The following is a description of a gene set: Human Gene Set: GSE32164_RESTING_DIFFERENTIATED_VS_ALTERNATIVELY_ACT_M2_MACROPHAGE_DN Genes down-regulated in macrophages: resting differentiated versus alternatively activated M2. studied in species Homo sapiens In response to microenvironmental signals macrophages undergo different activation, indicated as classic/M1 and alternative/M2 polarization. C-Myc transcription factor could be an essential player in M2 polarization. Functional relevance of c-Myc in M2 macrophage biology is investigated by evaluating the effect of 100-58F4, on the transcriptional profile induced on human macrophages by IL-4. from publication Pello OM, De Pizzol M, Mirolo M, Soucek L, Zammataro L, Amabile A, Doni A, Nebuloni M, Swigart LB, Evan GI, Mantovani A, Locati M (PMID 22067385), and this is the list of marker genes: RNF181, FBXW4, IL10RA, ETS1, SPG21, MPEG1, TMEM59, TSPAN32, RABAC1, FGL2, RPN1, RNGTT, ICAM1, CD82, CD28, MRPS5, IL4, ZFP36L1, CD22, MYCBP2 (NCBI Gene Id 55685), EIF4G2, CCR2, CXCR3, HLA-DRB1, EVI2A, PPID, HSPA5, PSMB9, HLA-B, ANXA1 (annexin A1), XPO1, UBE2D3 (NCBI Gene Id 7323), ID2 (inhibitor of DNA binding 2), HBB, E4F1, HLA-DQA1, SBF2, ST3GAL6, ANTXR2, VAMP5, SOCS2 (suppressor of cytokine signaling 2), SOAT2, F2R, CCRL2, DDX51, SKIC2 (SKI2 subunit of superkiller complex), ENTPD1 (ectonucleoside triphosphate diphosphohydrolase 1), ITGB2, PRDM1, SLC44A1, CYBA, PTGER4, TNK2, FASLG, ACTR2, COMMD7, RGS2, HPN, GOLGA5, JCHAIN, IRF5, C9orf40, BLK, PRKCD, BCL7B, GPC1, ARIH1, IL18RAP, MDFIC, DGAT1, PLBD1, SMPDL3A, ENPP1, ASNSD1, RNF34, RIN2, HLA-C, VOPP1 (NCBI Gene Id 81552), PTTG1IP, CYRIB, BHLHE40, GBP2, MFSD14A, CCR5, BCAP31, ITM2C, CRLF3, GNG10, AKAP8, UPF3B, COL5A1, PRDX6, FICD, SMNDC1, NABP1, AHNAK, ZBTB20, SPATA13, LMO4, CASP7, DNAJB9, HOPX, RAB24, BCL2A1, BTG3, KCTD12 (NCBI Gene Id 80710), NUDT16L1, ATF1, G3BP2, NRP1, KLRG1, MRPL44, GRK5, TK2, IL7R, CDC42SE2, SRGAP2 (NCBI Gene Id 440748), GATA3, ITM2B, RAB14, CLCN4, RASSF2, CUL3, LDAH, CKB, CASP8, TNFRSF18, PLIN2 (perilipin 2), EI24, CSTF3, RNF11, JKAMP, CDIPT, ASRGL1, MMP9, OTULINL, GPN3, EEA1, RNFT1, NMB, LMO2, FNTA, SEPHS2, EYA2, BMAL1, CYFIP1, HGSNAT, TENT5C, IGKC, ULK1, AP1G1, RELB, PPP1R15B, IREB2 (iron responsive element binding protein 2), TULP4, ERCC3, TMEM176A, RNASE4, CTSH, PLEKHB2, OSER1, SFT2D1, MARCHF6, CD72, UIMC1, IL10RB, TRAFD1, TRIM11, IFNG, KLRK1, PSEN2, DOK2, SLC4A7, IL18R1, SERPINB9, ITGB1, DMAP1, C1orf43 (NCBI Gene Id 91192), HNRNPH2, PRF1, DENND4C, VCAM1, UBA7, RELL1, NXF1, HSD17B11, INPPL1, WIPF1, SACM1L, SRGN, CD19, SERINC3, GNA13, SAFB, HACD3 (NCBI Gene Id 95112), DIAPH1, C6orf89, MKRN1, PARP8, SLC25A36